The following is a description of a gene set: species: Mus musculus The directed movement into, out of or within a cell, or between cells, by means of some agent such as a transporter or pore of quaternary ammonium compounds, any compound that can be regarded as derived from ammonium hydroxide or an ammonium salt by replacement of all four hydrogen atoms of the NH4+ ion by organic groups. Mouse Gene Set: GOBP_QUATERNARY_AMMONIUM_GROUP_TRANSPORT, and this is the list of marker genes: Slc6a12, Slc44a4, Slc16a9, Slc22a2, Slc22a16, Slc22a8 (solute carrier family 22 (organic anion transporter), member 8), Slc7a6 (solute carrier family 7 (cationic amino acid transporter, y+ system), member 6), Slc25a29, Slc6a20a, Slc22a5, Slc22a4, Slc22a1, Slc22a21, Slc25a20, Slc6a14, Slc22a3, Slc22a15, Slc25a19, Slc38a2